The following is a description of a gene set: Genes predicted to be targets of miRBase v22 microRNA hsa-miR-4781-5p in miRDB v6.0 with MirTarget v4 prediction scores > 80 (high confidence targets). Human Gene Set: MIR4781_5P from publication Chen Y, Wang X (PMID 31504780) studied in species Homo sapiens, and this is the list of marker genes: RARG, HOXB8, STPG3, C15orf39, URM1, ERO1B, RAB27A